Given this list of marker genes PHF12, FGFR2, FZD4, DDX5, ING4, TRIL, CELF2, ABCA1, CKB, MKRN1, COL7A1, CIT, TTLL5, MAP2K1, IGF2BP1, KLHL18, HIVEP2, RAB6A (NCBI Gene Id 5870), MEPCE, PTGES2, MEIS1, MBP, NRP1, SLC38A2, PLXND1, WSB1 (NCBI Gene Id 26118), EDNRA, FXR1, PTER (phosphotriesterase related), ST3GAL3, MMP2 (NCBI Gene Id 4313), TRAF7, ESRRA, SHROOM3, MINAR1, SRGAP3, FHIP1B, ADAMTS4, DMTF1, GIT1, RGS14, ZNF655, BAGE2, INA, ATRX, MEMO1, UBA1, CLK2, SORCS1, CLK3, GLP1R, EFNB2, DCUN1D4, HTR2C, CACNA2D3, HDAC5, RIMS3, OLA1, KLHDC10, PLAG1, G3BP2, FTH1, PIAS3 (protein inhibitor of activated STAT 3), DLST, SFPQ, DAG1, SHC4, FOXN3, SAMD5, APBB3, ETV5, FILIP1, YTHDC1, WASF2, GPX7, IVNS1ABP, WDR44, EIF4G1, SHANK2, ATP2B4, CDC27, CHRD, SENP2, STIP1, PRKACB, TOB2, SLC20A1, RAP2C, RAB6C, TNRC6B, GPATCH8, PBRM1, ACACA, TOP1, JADE1, SEMA5B, here is a description of the gene set: Human Gene Set: GGCAGTG_MIR3243P Genes having at least one occurence of the motif GGCAGTG in their 3' untranslated region. The motif represents putative target (that is, seed match) of human mature miRNA hsa-miR-324-3p (v7.1 miRBase). species: Homo sapiens